Given this list of marker genes Dgat1, Gdf15, Irs1, Obp2a, Tysnd1, Abcd2, Cnr1, Ppargc1a, Mtor, Fmo1, Acadvl, Plin5, Sirt4, Etfbkmt, Klhl25, Mir214, Nucb2, Abcd1, Fmo2, Pdk4, Appl2, Sox9, Akt1, Fabp1, Akt2, Lonp2, Fmo4, Mir199a-2, Pparg, Mlycd, Acacb, Fabp3 (fatty acid binding protein 3, muscle and heart), Mtln, C1qtnf2, Dbi (diazepam binding inhibitor), Acadl, Dgat2, Ppard, Twist1 (twist basic helix-loop-helix transcription factor 1), Irs2, Cpt1a, Acsl5, Mfsd2a, Abcb11, Ppara, here is a description of the gene set: Any process that modulates the frequency, rate or extent of fatty acid oxidation. studied in species Mus musculus Mouse Gene Set: GOBP_REGULATION_OF_FATTY_ACID_OXIDATION